Given this list of marker genes TP63, TMTC1, SRSF2, COL4A1, SLC12A2, ENTREP3, ZNF14, FRAS1, ENAH, KRTAP13-1, GPATCH2L, SNX3, CTSC, ARRDC3, EBF3, CLNK, PRIM1, ADRB2, TMEM252, THRB, PCDH9 (NCBI Gene Id 57123), B4GALT5, LHFPL2, UBE2B, WIPF2, HTR2A, SLC2A13, ATL2, BPTF, IL7, ZNF135, AXIN1, STEAP3, MPP1, KRBOX5, C3orf18, FRA10AC1, BICD2, ZNF844, RIC3, FGG, CPNE8, ZNF426, ADAM17 (NCBI Gene Id 6868), PAPOLA, EDRF1, RIMKLB, ROR2, GFM2, ZNF763, NEGR1, LNPK (lunapark, ER junction formation factor), ZNF124, KCNQ2, SMOX, ZNF268, INSYN2A, TGFBR1, OPALIN, ZNF490, TARDBP, IPO8, EBNA1BP2, CPD, XPO1, CATSPERE, MDGA2, PTP4A1, TIA1, STRA6, OTUD5, HAL, DCUN1D3, PRR15, AAK1, SLCO4C1, ALDH7A1, MPHOSPH9, LSM12, MACROD2, CD81, ZNF74, LAMC1, SMIM9, ZXDB, VASP, MTMR3, NAA15, SLC3A2, POGLUT1, SNX4, SLC7A11, DHCR7, SCAI, OPCML, SOS1, ARPP21, LPP, FRMD5, NAA50, SLC13A1, MED14, TBC1D1, FAM120A, DMXL2, LRATD2, ZNF594, NR2E1, IL17A, ABHD17B, LRRC28, TNFRSF21, WSCD2, GAB2, BTBD7, ZNF559, SLC12A6, ZNF367, CCDC177, here is a description of the gene set: studied in species Homo sapiens from publication Chen Y, Wang X (PMID 31504780) Human Gene Set: MIR6126 Genes predicted to be targets of miRBase v22 microRNA hsa-miR-6126 in miRDB v6.0 with MirTarget v4 prediction scores > 80 (high confidence targets).